Given this list of marker genes SEC61G, CSDE1, ARRDC3-AS1, CRELD1, LTC4S, WDR43 (NCBI Gene Id 23160), TBC1D8, NSRP1, CCNT2-AS1, SH3YL1, ALDH1A3-AS1, WDR75, CLTA, TRAF4, NAA80, CORO7, JARID2, PUSL1, ZNF3, TP53RK-DT, ST3GAL4, USP21, SGO1, APH1B, GTF3C4, KLHL7, PLA2G6, CITED2, PSENEN, GAB2, ZNF688, ATP6V1E2, UBE2D3, CLUH, TAF10, RANBP3, PNPLA8, PIWIL4, FUT4, LAMTOR4, RILP, FBXO38-DT, ENSG00000240207, EIF3M, PELP1-DT, RPN2, ZC3H4, MATCAP2, DNAJC4, THEM6, LRRK1, C1GALT1, DCTN6-DT, SH3PXD2A-AS1, UBQLN1, LYSET, CCS, SLCO4A1, RIMOC1, CNTROB, ZNF770, SEC22C, PCYT1A, CHKB-DT, WDR48, IMPACT, RPL23A, MFSD1, PRDM1, LAMC2, KLHL18, SLC36A1, SUGCT, SYNCRIP, ZBED4, CYSRT1, ZNF407-AS1 (ZNF407 antisense RNA 1), CENPL, TXNL4A, CDK5RAP1, TTI2, AZIN1, TRPT1, WWP2, KAT5, CD9, NCOR1, MRPL1, CUL2, DYRK1A, VOPP1 (VOPP1 WW domain binding protein), RBM27, MITD1, ATP6V0C, KLF6, FAM131B, CTNND1, CDC42SE1, BRAT1, FKBP5, TMEM134, HDGF, WDR37, SNORA7A, RUSF1-DT, ONECUT2, NAPEPLD, ACTB, ABCC4, MAN1A2, SLC33A1 (solute carrier family 33 member 1), NDUFA13, RNU2-2P, NEMP2-DT, SYN2, STX4, SLTM, SH2D5, TSNAX-DISC1, TPT1, KANSL1, POLR2L, ZDHHC21, NFKBIA, EFCAB2, LINC01588 (long intergenic non-protein coding RNA 1588), PRELID3A, SMC2, ULK3, FADS1, COX19, ITGA3, EXOSC3, GARS1-DT, NASP, IGF2BP3, NETO2 (neuropilin and tolloid like 2), DGAT2-DT, ARSK, HAR1A, AFAP1L1, FKBP11, CRYZL1, RALB, GGCTP1, EHF, H3C12, CEMIP (cell migration inducing hyaluronidase 1), KIAA1328, HNRNPDL, BEGAIN, MST1, EIF3K, ARPC1A, RBL2, DLEU1, RPS14, ALG5 (NCBI Gene Id 29880), LINC02028, TMEM167B, FRMD4B, THUMPD3-AS1, GCC1, ENSG00000260830, USP47, CES2, FOXP1, H2AX, SMARCAD1, R3HDM2, ZFAS1, MIR3190, DNAJB12, LINC02453, VPS37C, INCA1, KCMF1, DCXR, LAPTM4A, FBXW9 (F-box and WD repeat domain containing 9), DCLRE1B, DDX50, TM2D1, BMP2K, CCT4, ATIC, PXYLP1, ZNF70, SCFD1, PFKFB3, TRAP1, GFM2, SENP6, WDR27, AUP1 (NCBI Gene Id 550), RPL23AP95, SLC25A6, RASSF1, CCDC59, STPG4, CARNMT1-AS1, IL20RA, FOXM1, UBE2H-DT, ZNF629, CD44, GRHPR, KDM5B, TRMT61A, DUSP6, DDX3X, DOCK8, ABTB2, ODC1, EPS8, ACAA2, SH3PXD2B, TMEM69 (NCBI Gene Id 51249), MDN1, DUSP5 (dual specificity phosphatase 5), GID8, ARHGEF3, NEMF, PARP16, GATA2, DAB2IP, PPIL6, FRG1HP, CENPQ, AP5S1, DUSP23 (dual specificity phosphatase 23), PTPRB, HMGN4, CAPZB, LINC01342, TNFRSF10D, AGAP2-AS1, GOSR1, DCAF17, FOXP1-DT (NCBI Gene Id 126568846), ENSG00000233461, DAZAP2, SGO1-AS1, CACNB2, FAM131B-AS2 (NCBI Gene Id 100508744), PNMT, SH2D7, CDCA2, FANCI, MCOLN1, NDUFAF4, LRP2BP, MARS2, TMEM200A, KLF7, HOXA13, NOC4L, AHNAK, KCNK1, COL17A1 (NCBI Gene Id 7828), CDC73, LRATD2, FCHO2-DT, LPCAT3, FCHO2, BTN3A2, RNF13, LAPTM4A-DT, CELSR3, ALOX12B, TMX1, SLC38A6 (solute carrier family 38 member 6), PPP2R5B (NCBI Gene Id 5526), ENSG00000200288, HMGB1, HRAS, RANBP3-DT, IRF6, HNRNPD, STARD7 (StAR related lipid transfer domain containing 7), CCDC171, MIR762HG, SCRIB, GNA13, RPS6KB1, DGAT2, GGNBP2, LSS, PMS2CL, NME1, GOSR2-DT, ZDHHC8BP, SRD5A3-AS1, PTPMT1, DOLK, NDUFS3, ABHD2, RPS3, LIMD1, RFX1, MIR6853, IFT122, GFER, NAA25, IFT88, WDR35, TNPO3, RRM2, KCNC4, ANGEL2, CAPRIN2, CAMLG, HSPA4, CATIP-AS1, TMEM170A (NCBI Gene Id 124491), LRRC56 (NCBI Gene Id 115399), SPPL3 (signal peptide peptidase like 3), MYORG, PIERCE1, CASC11, SCARB1, XRCC6 (X-ray repair cross complementing 6), SLC26A11, RNU5A-1, LINC01719, ATE1, PMPCA, TEDC2-AS1, FANCA, FBXL18, ISY1-RAB43, DNAJC10, TRAM2-AS1, TMEM52, RNF123, RBBP4, MYBBP1A, CEP83, EMC8, BBS2, BBOF1, PTPA, IDI1, LINC02320, OCLN, PPP2R3B, AP1AR, TXNDC11 (NCBI Gene Id 96770), UCHL5, RBBP8, ENTPD4 (ectonucleoside triphosphate diphosphohydrolase 4), LINC00475, WDR87, CCNF, TMC6, RRP12, GALNT3, TUBB, RPLP0, MIRLET7BHG, RBM22, TPM4, ADAMTSL4-AS1, TMUB1, SETD1A, NORAD, OSBPL9, COPS5, EFHC1, ST3GAL1, NUBPL, RNU6-7, MBD4, CUL5, PRKAG2, MIR153-1, MPHOSPH6-DT, BUB1, HAR1B, SCAMP2, CCDC88C, ZNF581, GLB1, INSIG1-DT, PPP4R3B, TMEM147, DCUN1D5, ENSG00000245651, GRK6, ARF4, TAGLN2, THAP4, CCZ1P1, MIR4665, HMGN1, ODC1-DT, MRPS2, MAPDA, BZW2, WDR35-DT, USF1, PGRMC2, ABCA2, BRD9, MHENCR, LIN9, MCM7, FADS2, GPNMB, DAPK1, SEPTIN2, LINC02924, KTN1 (NCBI Gene Id 8109), CRACR2B, LINC00511, E2F5-DT, MIR584, RNF32, WEE1, SNHG3, PCIF1, IPO4, DIXDC1, MYO5C, DUS3L, MIR4512, REXO4, DAG1, RBM34, NEIL3, AGR2, DNAJA4, EXOSC7, VPS52, ITFG1-AS1, NSMCE2 (NCBI Gene Id 286053), VEZT, LINC02038, PLA2G2A, KRT8, HSPA9, SCARB2, RNU5E-6P, METTL3, PARVB, PHF5A, NAPRT, EMP1, GPHN, YTHDC1, RN7SKP193, FAAP20, LMNTD2 (NCBI Gene Id 256329), THUMPD1, C19orf38, INO80E, PANK1, U2AF1L4, MRPL36, OSGEP, ENSG00000272195, PDHB, TRAPPC1, PSMD14-DT, FAHD1, DCTD, RHOQ, GNB2, CLDN7, ZMAT5, POLD3, COLGALT1, FUZ, JMJD7, CPSF4, PVT1, ZNF621, PCDH1, GRPEL1, SSU72-AS1, LINC02846, TUBD1, MMP11, MROH8, CEP135, AVPI1, PLK4, GRK4, MTHFR, UBE2M, ICA1-AS1, GRHL3-AS1, PALD1, SCNN1A, ENSG00000275740, LAMP1 (lysosomal associated membrane protein 1), NUP188, RNF217-AS1, WDR11-DT, CLCN6, LRRC14, BLM, RO60, FAF2, APEH, TSSK6, DCXR-DT, MIR3613, ACTN4, H2BC9, SRI, MRPS27, SOCS3, HOXA10, PHF7, TOMM5, PTCD1, ATP5PD, WASHC2C, VTRNA1-2, DHDDS, TECPR2, CSRNP2, RUSF1, NDRG2, ZNRF2, DBF4, SNRPD3, MTA2, SF3A2, CTBP2, STARD10, TMEM268 (transmembrane protein 268), CLN3, POLR1B, EIF3J-DT (EIF3J divergent transcript), RPS29P16, COA6, NUDT6, DGKA, DDX39A, IMMT, CREB3, CLN5, H2BC26, ZFP90, ARPC5L, PRDM11, MRPS6, FOSL2, KCTD9, ENSG00000266401, LIMS1, SERP1, ANKHD1-EIF4EBP3, NFE2L2, TTPAL, IFIH1, ASH1L, TLN1, KCTD2, PSMC3IP, GPRC5D-AS1, SLC35C1, RN7SL3, NDST1-AS1, ARL8B, PSD, METTL6, MRPL30, RNF217, NMRAL1, DCTN2, CEP83-DT, FLVCR1-DT, BRPF1 (bromodomain and PHD finger containing 1), GBA2, DUS4L, SMAD1, ARHGDIA, FGD6, NUP98, ADGRV1, PYM1, SESN1, NUB1, INO80D, KLHDC2, PSMB7, UBQLN1-AS1, SMYD5, IGFL4, LIPT2, PRR12, UBE2D3-AS1, SNHG21, CNIH1, TMED1, AP1AR-DT, BTF3-DT, RNU6-728P, FAM156A, LTBP3, CHTOP, PLEKHG3, ZNF138, IP6K2, CLNS1A, PXN-AS1, NME1-NME2, MRPL40, ARHGAP5-AS1, YAP1, TNKS, MPZL1, ACOXL, TAF7, TPRN, UBE2H, CIB2, PLEK2, OPLAH (NCBI Gene Id 55579), A2M-AS1, TTF2, ANKHD1, ARHGAP5, SH3RF1, ASNSD1, PLSCR4, TPI1P2, HNRNPUL2-BSCL2, SMARCAD1-DT (SMARCAD1 divergent transcript), APH1A, KLHDC1, ELMOD2, CDK8, TRIP13, TRMU, FLNC-AS1, PKNOX1, DNAJC27-AS1, KLC2, GALNS, TRIM62 (tripartite motif containing 62), NMD3, ANKMY2, DDX6, TRMT2A, MRGBP, PRC1, EPB41L5, OPA3, IDNK (NCBI Gene Id 414328), TMEM18, PRR7, ZCWPW2, TRMT112, NEURL4, USF3, CCT6A, CXCL2, BCCIP, MYO19, CRTC3-AS1, ENSG00000277020, AGR3, PGAM1, AAK1, ITGA6 (NCBI Gene Id 3655), COBLL1, HSPA5, TMEM109 (transmembrane protein 109), CAPN1, ACSL1, DIP2A, GOLGA5, COIL, HTRA2, FADD, SLC3A2, SLC12A8, STEAP1, VEGFA, SLC16A9, RAD51AP2, DPP8, CCT6P1, SEPTIN9-DT, DNAJB1 (NCBI Gene Id 3337), SDCBP2, TACC3, ARID2, RPL7L1, BRCA1, H3-3A, TEDC2, PDCD5 (programmed cell death 5), PRR15-DT, TM4SF1-AS1, LARP1, AFG2A, SNAP47, LINC01703, GCA, TXNDC5, SNX4, ZNF76, RAD51, KIF3A, SECISBP2, CAPN1-AS1, SPC24, KIF22, SNIP1, PRR15, ARRDC3, PHF3, ENTPD4-DT, KIF23-AS1, TTC9C, REX1BD, DMTF1-AS1, NACA, TMEM175, HCG14, NDRG3, TNPO1, TSPO, ARF1, LINC01852, TACC1, PUM2, SERPINB8, SSC4D, NPDC1, SLC4A7, CD101-AS1, PRR7-AS1, H2AZ2, DBI, DHX36, RASSF7, TUBGCP6, ZBTB1, SET, MFSD3, TRIP6, PRMT9, BBIP1, TFR2, ARF5 (NCBI Gene Id 381), ARL6IP4, CNTFR, DARS1-AS1, CAPS2, DHPS, CENPT, TFAP2A, RHOT2, YIPF7 (NCBI Gene Id 285525), ANLN, LNCRNA-IUR, DDX21, FAM21FP (NCBI Gene Id 648708), THAP5, MTHFD2L, PPP3R1, YARS1 (NCBI Gene Id 8565), CDK13-DT, ZNF668, LINC01269, ASTILCS, LINC-PINT, ZBTB25, CRAT, C1orf43, NADK, TNS3, STT3B, NAGA, DNAJA3, NUCB2, FARSA, PRCC, ACP1, NEK8, YWHAB, PNPLA3, EPB41L4A, TMPPE, ZNF775, AP2B1 (NCBI Gene Id 163), ITGAV, ANAPC7, NOSIP, HNRNPUL2, FAAP100 (NCBI Gene Id 80233), SLC11A2, SYNRG, DESI1, COL6A4P1, PIK3R2, HYAL3, NUDCD2, ACAP3, COX5B, ZNF646, ATAD2B, HSP90AB1, TPI1, POC5, JMJD4, PLEKHG2, LRP3, LINC00938, ABHD10, BOD1 (biorientation of chromosomes in cell division 1), KATNA1, KALRN, C6orf141, NUTF2, CNPY2-AS1, ZNF436-AS1, TMCO4, KLHL7-DT, CCDC163, ENOPH1, ZNF639, TOLLIP, MADCAM1-AS1, KCNC4-DT, RMDN1, SUCLG1, TPT1-AS1, TTC41P, IZUMO4, E2F8, PELP1, ST3GAL1-DT, LINC00479, ATG4B, HROB, GTF3C2, PIF1, SH3TC2-DT (SH3TC2 divergent transcript), BMI1, KIF9, FNBP1P1, NEMP2, NBR1, MSMO1, LRRC1, ZNF767P, SATB2-AS1, UNC13D, FAM174C, TATDN1, SSH3, DDX51, SKIDA1, ANKRD63, RAD23A, NXT1, GLT8D2, CAMTA1-DT, CFDP1, SMPD2, CFL1 (NCBI Gene Id 1072), S100PBP, PIK3C2A, SGK2 (serum/glucocorticoid regulated kinase 2), NSA2, PTS, FAM221A, RASA1, FOXA2, OAT, TOR1B, MAP4K1, CNPPD1, FXYD3, TMEM223, ZYX, ENSG00000273077, DGCR8, TRMT5, REPIN1, TAB2, C19orf12, ABCC11, HCFC2, TM9SF1, CIAO2B, ZNF165, RHEB, USP22, TMEM62, NUDT22, HECTD4, SNHG5, CISD3, PDCD7, SULT1A1, PTPRG, HNRNPD-DT, ICE1, NDUFB9, SNORA24B, METTL8, MANF, TMEM219, MIR194-2HG, EIF3F, CLDN4, EZH1, AGL, JMJD7-PLA2G4B (JMJD7-PLA2G4B readthrough), FBXO31, PAK6, GNPTAB, C10orf95-AS1, TESK1, STX10, ARAP1, LONP2, HNRNPL, TRIM35, PSMD14, SUPT16H, PDE4D, MIR3197, DRAM1 (DNA damage regulated autophagy modulator 1), RNF130, QPCTL, ZDHHC3, XYLT2, LY75-CD302, HAGHL, SKIC3, ACTR2, MCF2L-AS1, CCDC71, HOXA9, RPS23, TINAGL1, NFU1, DNAJC21 (NCBI Gene Id 134218), SHOC2, KCTD3, CCDC87, C15orf61, TAF5L, LYRM2, CLPX, CCDC78, RPS18, TMCO1, DHX8, NEAT1, L3HYPDH, NDUFA10, GTF3C6, ADPRM, TENT4A, ZNF48, PRDX5, MTG2, JKAMP, ITGB8, RPL32, EIF4ENIF1, CSPP1, C7orf50, COPS7A, LRIG2-DT, TM4SF1, DNAJB9 (NCBI Gene Id 4189), FOXJ2, MTMR11, SNRNP200, ITSN1, MUS81, MAML3, LINC02352, MIR5787, GOSR2, SLC18B1, CRYBA2, MYO10, HIRIP3, TUBB4B (tubulin beta 4B class IVb), RMC1, DIS3L, R3HDM2-DT, RBM6, SMARCA4, PLEKHJ1, MOB3A, PPP1R35-AS1, EXO1, RASSF1-AS1, PSTPIP2, MFSD4B-DT, HIRA, HDAC10, KNL1, SPRY1, HERC6, MRM3, TMEM117, COG5, TRAM2, PDCD4-AS1, CHCHD4, EIF2AK1, METTL25, EMC4, AP1G1, CDC42BPA, EMILIN2, GUF1, RAB40C, HM13, OLMALINC, TMEM131, PNPLA6, BLOC1S6, RCC1, TMEM165, CTDSP1, FANCC, PFDN4, YWHAZ, RNH1, NR2F2, LINC00112, RBM33-DT, PPIEL, AP2S1, ALDH3A2, NFIB, SUPT3H, ZFP36, AK3, MAP1LC3B, SYMPK, GATD1-DT, CDPF1P1, CKAP2, PSEN1, SLC1A5, SYNJ2, AMZ2, NEPRO, CS, TSN, RTKN, BANP, ISOC2, RANBP2, RCN1, TRMT12, E4F1, DCTN6, ZZZ3, LRIG2, CREBZF, PTMA, BAP1, PPP4R3B-DT, PPP1R35, MPLKIP, HNF4G, HNRNPUL1, RETREG2, WASHC5, NOP14, CHRNA7, HMOX2, TRAPPC5, SLC16A13, DST, CEP63, RACGAP1, ANAPC13, MKLN1-AS, APEX1, SLC46A1, WASL, FLVCR1, ABHD17C, SNORD13, DNAJA4-DT, RAD51-AS1, RAD52, PAAF1, ZNF436, LINC00974 (long intergenic non-protein coding RNA 974), BICD2, ZNF768, SMPDL3A, MAILR, DARS2, DNAJC9-AS1, COA6-AS1, SIPA1L3, UROS, DDX31, ATN1, COMMD1, ZBTB8OS, RN7SL2 (NCBI Gene Id 378706), AP4M1, VPS35, SLC25A39, H3C7, OXSR1, LAMA3, HDAC1, HMGB2, ALOXE3, H3-3A-DT, MKS1, MRPS23, MYH10, ELMO3, SEC61G-DT, NDUFA5, INSIG1 (insulin induced gene 1), ADISSP, IQCB1, ARHGAP27, ORC6, GRHL3, VCP, ANKRD37, SLF2, ISY1, NDST1, ANKRD10, CDK12, FBXO7, KMT5C, KANK1, ISG15, NUBPL-DT, PUF60, MCF2L, ANKHD1-DT, PSAT1, ENSG00000260136 (novel transcript), MMACHC, SEPSECS-AS1, MEF2D, TYK2, RABGGTB, ATP5ME, HAGH, PSMG1, AZI2, TSNAX, SENP8, TEX264, BACE2, MON2, ZNF367, UBAP2L, RAB1A, RNU7-27P, CHKB, UBE2D2, DNAJC27, SLC5A3, UBXN2A, ZNF280D, MYO9A, TMSB10, DYNC2I1, PICART1, TMEM200B, RER1, NRP2, PSPH, TRIM4, KLHL8, PTPRA, SESN3, HIPK3, NEPRO-AS1, IRF2BP2, DVL2, HOXA10-AS, POLB, HACD3, STRIP1, LAMB2, SNORD42B, PSMC2, LNCOC1, SEH1L, TRIM7-AS2, SH3TC2, H2AZ2-DT, KLHL35, TPGS2, TBK1, BCAT2, TRABD2A, MCM3AP-AS1, FKTN-AS1, MAP3K14, DCAF4, NEK9, CHCHD10, RUSC2, SLC41A2, TMX2, PCBD2, PELATON, TNFSF9, HCN3, GPBP1L1, MAPK14, MRPL15, AP4S1, SNRPD2, EAF2, FBXO38, ENTR1, CDK13, RTN4, WDR11, PCBP1-AS1, CTSO, SNORD15A, EML6 (NCBI Gene Id 649652), ANXA4, CINP, ENSG00000241525, TSPAN4 (tetraspanin 4), DNLZ, MFSD4B, PELO-AS1, PAK6-AS1, PIMREG, IQCH-AS1, SLC12A9, RARA, MXD3, WDR74, UQCR11, TMBIM6, KDM6B, TRAPPC9, CAMTA1, SLC2A8, COMMD9, SLC7A6, ITGB5, ENSG00000213963, LPP-AS2, CFAP20DC, NEDD4L, TMEM147-AS1, PYCR2, TPP2, SLC38A4-AS1, GALNT10, ADGRE2, LY75, EXOSC8, POLM, EED, GRPEL2-AS1, NLE1, RAVER1, CARINH, TXNRD2, VDAC2, EMC6, here is a description of the gene set: species: Homo sapiens from publication Yevshin I, Sharipov R, Kolmykov S, Kondrakhin Y, Kolpakov F (PMID 30445619) Genes containing one or more binding sites for (FOXD2) in their promoter regions (TSS -1000,+100 bp) as identified by GTRD version 20.06 ChIP-seq harmonization. Human Gene Set: FOXD2_TARGET_GENES